Given this list of marker genes Afg3l2, Afg3l1, Apool, Immt, Uqcc3, Apoo, Dnajc11, Oma1, Chchd6, Micos13, Tafazzin, Slc25a46, Chchd10, Samm50, Micu1, Adck1, Micos10, Pink1, Opa1 (NCBI Gene Id 74143), Chchd3, Letm1, here is a description of the gene set: Mouse Gene Set: GOBP_CRISTAE_FORMATION The assembly of cristae, the inwards folds of the inner mitochondrial membrane. studied in species Mus musculus